The following is a description of a gene set: Mouse Gene Set: REACTOME_SEMA4D_MEDIATED_INHIBITION_OF_CELL_ATTACHMENT_AND_MIGRATION Sema4D mediated inhibition of cell attachment and migration studied in species Mus musculus, and this is the list of marker genes: Sema4d, Plxnb1 (NCBI Gene Id 70220), Arhgap35, Rhoa, Rac1, Rnd1, Met, Rras